Given this list of marker genes AK2, PEF1, EPB41 (NCBI Gene Id 2035), MIR4420, SNORA44, HSPD1P14, LINC01226, EEF1A1P46, NKAIN1, RN7SKP16, SYNC, TAF12-DT, RN7SL122P, PEF1-AS1, SESN2, ZBTB8A, NHSL3, TXLNA, MECR, FABP3, MIR3605, XKR8, C1orf94, YTHDF2, CSMD2-AS1, SMPDL3B, S100PBP, SPCS2P4, RPL21P22, SRSF4, DNAJC8, ENSG00000305127 (NCBI Gene Id 105378629), RBBP4, EYA3, DNAJC8P4, TSSK3, ENSG00000308292, RN7SL559P, SNORA73A, TINAGL1, TRNAU1AP, PHC2-AS1, RNU11, TMEM200B, RNF19B, RNA5SP42, PUM1, SNRNP40, SNORA61, RAB42, BSDC1, FAM229A, TAF12, MIR4254, HPCA, RNU6-40P, KHDRBS1, MTMR9LP, FNDC5, RNU6-176P, OPRD1, RN7SKP91, SNORD99, SNHG3, RNU6ATAC27P, COL16A1, ENSG00000252777, IFI6, PRDX3P2, SCARNA1, ARL8BP2, RNU6-424P, MATN1-AS1, TMEM54, SERINC2, LRRC37A12P, PTAFR, PTP4A2, RPA2, AZIN2, CSMD2, STX12, ENSG00000305901, PHC2, LINC02574, ENSG00000288678, LINC01778, SELENOWP1, ENSG00000235143, RN7SL371P, CHMP1AP1, HMGB4, TMEM39B, LINC01756, SNORA73B, RPEP3, YARS1, ENSG00000305107, LCK, ATP5IF1, TLR12P, RCC1, SPOCD1, RNU6-949P, FGR, FAM76A, SNORA16A, LDC1P, PTPRU, HCRTR1, PPP1R8, MATN1, CCDC28B, A3GALT2, ZBTB8B, ZBTB8OS, MARCKSL1, GMEB1, IQCC, LINC01648 (NCBI Gene Id 101929406), ZNF362, SNHG12, GAPDHP20, MED18 (mediator complex subunit 18), DCDC2B, EIF3I, LAPTM5, ZCCHC17, FAM167B, TRIM62, SDC3, ZSCAN20 (zinc finger and SCAN domain containing 20), AHDC1, PHACTR4, TMEM234, ADGRB2, KPNA6, THEMIS2, HDAC1, MIR5585, RNU6-1245P, here is a description of the gene set: species: Homo sapiens Human Gene Set: chr1p35